Given this list of marker genes Glcci1, Deptor, Sptssb, Caml, Tmem108, Ptchd1, Nucks1, Sft2d1, Ptprb, Avl9 (NCBI Gene Id 78937), Ptgfrn, Eif4a1, Apol10b, Klhdc10, Prkar2b, Serpini2, Srsf6, Snx27, Dedd, Phf14 (PHD finger protein 14), Aff4, Plagl2, Bcl9, Sorbs2, Ext2, Pdpk1, Ret, Csrnp2, Matr3, Usf3, Rab2a, Zbtb11 (zinc finger and BTB domain containing 11), Amot, Trp63 (NCBI Gene Id 22061), Pcdh8, Dsp, Sobp, Eif4a2, Cradd, Gatad2a, Macf1, Tef, Mbnl3, Prmt6, Ccar2, Dr1, Cbfa2t3, Tent4b, Hsbp1, Arid3a, Hsbp1l1, Cacnb4, Neo1, Bbx, Casz1, Rabgap1, Zswim6, Naip6, Ppfia2, Mtss1, Usp16, Serp1, Il3, Slc5a9 (solute carrier family 5 (sodium/glucose cotransporter), member 9), Ppig, Tspan3, Mthfd2, Nr3c2, Gprc5b, Nf1, Kitl, Sft2d3, Elovl5, Adam10, Ints6, Alkbh5, Trim67, Sub1, Gjc3 (gap junction protein, gamma 3), Pdia6, Glis3, Cnot4, Gpr65, Kctd3, Mylk4, Sh2b3, Map2, St6galnac4 (NCBI Gene Id 20448), Borcs6, Prr9, Serpinb1b, Foxp4, Dab2, Lipf, Hycc2, 1700025G04Rik, Trpv1, Ryr3, Colgalt2, Mitf, Rap1a, Vangl1, Apol11b, Golph3, Dnajc14, Vav1, Pgm2l1, Hus1, D630045J12Rik, Zfp275, Socs2, Ctcf, Fam91a1, G3bp2, Mtmr4, Rnf14, Sema6d, Zfp711, Zmym3, Scin, Acer3, Ube2v2, Rnf19a, Chtop (chromatin target of PRMT1), Sdk1, Dach2, P4ha2 (procollagen-proline, 2-oxoglutarate 4-dioxygenase (proline 4-hydroxylase), alpha II polypeptide), Ralbp1, Lratd1, Kdm4b, Minar1, Wipi2, Kdm3b, Nup153, Garre1, Tnpo1, Ssr1, Hpcal4, Rai14, Myo5a, Lonrf1, Ptprj, Orc3, Csnk1d, Ago2, Spice1, Utp15, Rad23b, Tmx4, Phospho2, Stt3a (STT3, subunit of the oligosaccharyltransferase complex, homolog A (S. cerevisiae)), Dlgap4, Eif1ad, Tead1 (NCBI Gene Id 70301), Rftn1, Rbbp5 (retinoblastoma binding protein 5, histone lysine methyltransferase complex subunit), Htr3a, Hs6st3, Aak1, Tns1, Hapstr1, Cbfa2t2, Prps1, Coro1a, Pak2, Usp34, Pcdhga12, Vcan, Vmn2r89, Klhl20, Tmem18, Fmod, Ptbp2, Inpp4b, Pak5, Cpd, A1cf, Rsbn1, Ocln, Fbxl5, Ago1, Clip2, Ttpal, Ric8b (NCBI Gene Id 237422), Zdhhc13, Adam7, Ap4e1, Trim16 (tripartite motif-containing 16), Saa4, Phf6, Tm9sf3, Rab38, Plekhb2, Mbnl1, Med13, Gatm, Calb1, Pafah1b2, Rap2a (NCBI Gene Id 76108), Plcb1, Gbx2, Rif1, Gls2, Zfp609, Sde2, Gls, here is a description of the gene set: Mouse Gene Set: MIR_742_3P Genes predicted to be targets of miRBase v22 microRNA mmu_miR_742_3p in miRDB v6.0 with MirTarget v4 prediction scores > 80 (high confidence targets). studied in species Mus musculus from publication Chen Y, Wang X (PMID 31504780)